Given this list of marker genes Nherf1, Lrrc52, Lrg1, Lrrc55, Lrrc38, Lrrc26, Akt1, Stim1, Smdt1, here is a description of the gene set: Direct interaction with a channel (binding or modification), resulting in its opening. A channel catalyzes energy-independent facilitated diffusion, mediated by passage of a solute through a transmembrane aqueous pore or channel. studied in species Mus musculus Mouse Gene Set: GOMF_CHANNEL_ACTIVATOR_ACTIVITY